The following is a description of a gene set: The chemical reactions and pathways involving carnitine (hydroxy-trimethyl aminobutyric acid), a compound that participates in the transfer of acyl groups across the inner mitochondrial membrane. species: Mus musculus Mouse Gene Set: GOBP_CARNITINE_METABOLIC_PROCESS, and this is the list of marker genes: Acadm, Crot, Acadl, Bbox1, Cpt1a, Cpt1c, Cpt2, Crat, Cpt1b, Slc22a5, Aldh9a1, Slc22a4